The following is a description of a gene set: species: Mus musculus Any process that activates or increases the frequency, rate, or extent of toll-like receptor 7 signaling pathway. Mouse Gene Set: GOBP_POSITIVE_REGULATION_OF_TOLL_LIKE_RECEPTOR_7_SIGNALING_PATHWAY, and this is the list of marker genes: Slc15a4, Rsad2, D1Pas1, Treml4, Tasl, Ddx3x, Ptpn22